The following is a description of a gene set: part of: SLC transporter disorders species: Homo sapiens SLC40A1 (MTP1 aka ferroportin or IREG1) is highly expressed on macrophages where it mediates iron efflux from the breakdown of haem. SLC40A1 colocalises with ceruloplasmin (CP) which stablizes SLC40A1 and is necessary for the efflux reaction to occur. Six copper ions are required by ceruloplasmin as a cofactor.<br>Defects in SLC40A1 can cause hemochromatosis 4 (HFE4; MIM:606069), a disorder of iron metabolism characterised by iron overload. Excess iron is deposited in a variety of organs leading to their failure, resulting in serious illnesses including cirrhosis, hepatomas, diabetes, cardiomyopathy, arthritis and hypogonadotropic hypogonadism. Severe effects of the disease don't usually appear until after decades of progressive iron overloading (De Domenico et al. 2005, 2006, 2011, Kaplan et al. 2011). Reactome Pathway: Defective SLC40A1 causes hemochromatosis 4 (HFE4) (macrophages), and this is the list of marker genes: SLC40A1 (solute carrier family 40 member 1), CP